The following is a description of a gene set: studied in species Homo sapiens Human Gene Set: GSE16385_ROSIGLITAZONE_IL4_VS_IFNG_TNF_STIM_MACROPHAGE_UP Human CD14 positive monocytes were purified from healthy volunteers’ blood and cultured in vitro for 4, 12, 24, 72 hours. While culturing, macrophages were activated alternatively with interleukin-4 (IL-4 100 ng/ml) or classically with interferon-gamma (IFNg 100 ng/ml)+tumor necrosis factor (TNF 50 ng/ml) or left without activation. Simultaneously, macrophages were also treated with vehicle (DMSO:ethanol) or 1mM synthetic PPARg agonist, Rosiglitazone. We used Affymetrix microarrays (U133Plus 2.0) to analyze activation and PPARg-induced gene expression changes. Genes up-regulated in macrophages (12h): rosiglitazone and IL4 versus IFNG and TNF. from publication Szanto A, Balint BL, Nagy ZS, Barta E, Dezso B, Pap A, Szeles L, Poliska S, Oros M, Evans RM, Barak Y, Schwabe J, Nagy L (PMID 21093321), and this is the list of marker genes: MVP, PIK3IP1, MICAL1, DNAJB14, TRADD, JAK1, PITPNC1, CLDN1, MED23, TSPYL1, PIGK, ALDH5A1, MAN2A2, WDR26 (WD repeat domain 26), CLEC16A, PER2, BIRC2, KDM5A, EDAR, SH3YL1 (SH3 and SYLF domain containing 1), ACTN1, HSPA1L, ALMS1, UTP14C, PPP2R5E, COQ10B, SLC9A6, CAB39 (calcium binding protein 39), ARID4B, CCR7, ZNF276, HIVEP1 (NCBI Gene Id 3096), TYW1, DENND2D, KLF10, PPM1B, CD40LG, SGSH, RAB3GAP1, HERPUD1 (NCBI Gene Id 9709), SUN1, BTN2A1, SLA, EGR2, THUMPD1, CDK17, ALDOC, PFKFB3, ISG20, TSC22D2, SLC30A1 (NCBI Gene Id 7779), NPTN, PRPF40A, RAB33A, GCH1, CHD7, AP1G2, SNX11, FYN, RNF4, NSMF, IL23A, GNA14, COL6A3, ZFP36L1, QPCT, NELL2, LTN1, ZSWIM8, SEC24B, FLT3LG, HCP5 (NCBI Gene Id 91955), PTPRC, PTPN4, SEMA4D, TOB1, DUSP4, INPP5F, RNF6, STAG1, CD5, RIGI, SUPT20H, SLAMF1, HAGH, MYOM2, ZNF12, ING3, KRAS, ERBIN (erbb2 interacting protein), NAA16, HAUS3, CCR9, MAML1, BANP, ADD3, BACH2, MOB4, TENM1, SLC2A3, TRAK2, ID2, CAMK4, STK17B, IFI44L, LRRC8B, UNC50, SKAP1, LTA, TMEM204, PLLP, ANKRD55, GCC2, TIAM1, CLEC2D, GIMAP4, MLXIP, IL6ST, PLN, NCOA3, NPAT, GPR18, FBXL4, PIP4K2C, DPEP2, STX16, SCML1, ABCC10, ATF1, GVINP1, DYRK2, PANK4, PASK, AP5Z1, SUPT7L, SHC1, OSBPL8, RCAN3, VPS13B, ZNF263, SLC16A10, BCL2A1, GOSR1, NUDT9, DDX60, ANKRA2, GZMA, NRIP1, CEP170, DOCK10, ZHX2, PARP12, CFP, DZIP3, ACVR1, CREBBP, N4BP2L2, TNFSF14, RBM38, KDM4B, ATF7IP, S1PR1, TTC31, CCNT2, IL2RB, CEMIP2, GPR183, MARK3, ABCB1, CHMP7, JRKL, PTK2, LRRN3, BTN3A3, ASXL1, NR4A2, HTR2B, IDS, SPG11, TBC1D2B, KRBOX4, KDM2A, TNFRSF25, USP36, MTUS1, HBP1, PCMTD2, GALNT10, NAB2, PLK3 (polo like kinase 3), TPST2, KLF2, GBP1, IL6R, SARDH, ZFYVE16, BAG3, NAXD, SPOCK2, PRPF3